The following is a description of a gene set: studied in species Homo sapiens Reactome Pathway: Unfolded Protein Response (UPR) The Unfolded Protein Response (UPR) is a regulatory system that protects the Endoplasmic Reticulum (ER) from overload. The UPR is provoked by the accumulation of improperly folded protein in the ER during times of unusually high secretion activity. Analysis of mutants with altered UPR, however, shows that the UPR is also required for normal development and function of secretory cells.<br>One level at which the URP operates is transcriptional and translational regulation: mobilization of ATF6, ATF6B, CREB3 factors and IRE1 leads to increased transcription of genes encoding chaperones, while mobilization of PERK (pancreatic eIF2alpha kinase, EIF2AK3) leads to phosphorylation of the translation initiation factor eIF2alpha and global down-regulation of protein synthesis.<br>ATF6, ATF6B, and CREB3 factors (CREB3 (LUMAN), CREB3L1 (OASIS), CREB3L2 (BBF2H7, Tisp40), CREB3L3 (CREB-H), and CREB3L4 (CREB4)) are membrane-bound transcription activators that respond to ER stress by transiting from the ER membrane to the Golgi membrane where their transmembrane domains are cleaved, releasing their cytosolic domains to transit to the nucleus and activate transcription of target genes. IRE1, also a resident of the ER membrane, dimerizes and autophosphorylates in response to ER stress. The activated IRE1 then catalyzes unconventional splicing of XBP1 mRNA to yield an XBP1 isoform that is targeted to the nucleus and activates chaperone genes. part of: Cellular responses to stress, and this is the list of marker genes: ATP6V0D1, DNAJB9, EDEM1, TPP1, ACADVL, EXOSC1, EXTL2, FKBP14, SSR1, EXOSC6, IGFBP1, SRPRA (SRP receptor subunit alpha), EXOSC3, EXOSC9, DNAJC3, PDIA6, NFYA, SRPRB, CREB3L3, LMNA, DCP2, MBTPS2, KDELR3 (KDEL endoplasmic reticulum protein retention receptor 3), GOSR2, DDX11, CREB3L1 (NCBI Gene Id 90993), GFPT1, DNAJB11, EXOSC5, DIS3, CREB3L2, MYDGF, CXCL8, EIF2S1, ARFGAP1, ADD1, TLN1 (talin 1), SHC1, CXXC1, SEC31A, CREB3L4, DCSTAMP, YIF1A, SERP1, ATF3, NFYB, EXTL3, EXOSC2, EXTL1, EXOSC4, ATF4, HSPA5, CALR, CREBRF, PREB, DDIT3, HERPUD1, EIF2S3, MBTPS1, TSPYL2, ZBTB17, HYOU1, CUL7, ERN1, PDIA5, TATDN2, HSP90B1, SULT1A3, CCL2, EXOSC7, EIF2S2, ATF6B, ASNS, CREB3, KLHDC3, PARN, HDGF, KHSRP, GSK3A, CEBPB, CTDSP2, SYVN1, PLA2G4B, EIF2AK3, EXOSC8, DCTN1, XBP1, WFS1, NFYC, WIPI1, ATF6, PPP2R5B, CEBPG